The following is a description of a gene set: Genes containing one or more binding sites for (ZNF532) in their promoter regions (TSS -1000,+100 bp) as identified by GTRD version 20.06 ChIP-seq harmonization. Human Gene Set: ZNF532_TARGET_GENES from publication Yevshin I, Sharipov R, Kolmykov S, Kondrakhin Y, Kolpakov F (PMID 30445619) studied in species Homo sapiens, and this is the list of marker genes: SEC61B, NSMF, EGLN3, AIMP1, TSNAX, RIOK2, MRPL44, FABP6-AS1, POLR3F, PRKG2-AS1, CAMKMT, CDC40, ATP5MG, DTNB, SMC2, PHF5A, PNO1, EPB41, DZANK1, NDUFA4, SUDS3, ENSG00000233461, SNORD58A, GOSR2, GCLM (glutamate-cysteine ligase modifier subunit), C19orf48P, OSTC, RPL32P3, BLCAP, ACO2, FARSB (phenylalanyl-tRNA synthetase subunit beta), HSPA9, PES1, NUP85, SRD5A1, WASF1, NOX4, SNORD58B, NUP205, PREPL, RPL17-C18orf32, DCTN1, UPF2, TSNAX-DISC1, ADAMTS7P3, RPL32, DBT, CNPY3, GOSR2-DT, TAF6, CNPY4, RNF187, DNAAF10, RPL21, RPL17, HOXB7 (NCBI Gene Id 3217), SNRPB, CTBP2, TBCK, FGD3, NSUN2, ALG2, TMEM91, BAG6, CDCA7